The following is a description of a gene set: Mouse Gene Set: NABA_MATRISOME_HYPERPLASTIC_PANCREATIC_ISLETS species: Mus musculus from publication Naba A, Clauser KR, Mani DR, Carr SA, Hynes RO (PMID 28071719) Matrisome proteins detected in significantly higher abundance during the hyperplastic stage of insulinoma progression compared to normal islets and relative to insulinomas (RIP-Tag2 model). In this study, we aimed to characterize changes in the extracellular matrix (ECM) composition during insulinoma progression using a quantitative proteomics approach. To do so, we chose a mouse model of insulinoma, a subtype of pancreatic neuroendocrine tumors, characterized by the expression of SV40 large T antigen (Tag) in pancreatic beta-cells driven by the rat insulin promoter (RIP) (RIP1-Tag2 model). This model follows a well-defined timeline of tumor progression: hyperplastic islets appear by 4 weeks of age, angiogenic islets by 7-9 weeks, solid tumors at 10 weeks, and large and invasive adenomas by 12-13 weeks. Using quantitative proteomics based on isobaric peptide labeling (iTRAQ), we profiled the ECM proteomes or matrisomes of various stages: normal pancreatic islets, hyperplastic islets, angiogenic pancreatic islets, and insulinomas. We focused on ECM and ECM-associated proteins along with proteins found in only one of the two replicates but with at least two unique peptides. Applying a moderated F-test, we identified proteins detected in statistically significantly different abundance in tumor samples (hyperplastic, angiogenic islets or isulinomas) as compared to normal pancreatic islets. The gene set lists the matrisome proteins detected in significantly higher abundance during the hyperplastic stage of insulinoma progression as compared to normal islets and later stage insulinomas., and this is the list of marker genes: Prss1, Dmbt1, Serpini2 (NCBI Gene Id 67931), Vwa5a, Prss1l, Lgals1, Try10, Reg1, Reg2, Anxa3, Anxa7 (annexin A7), Cela2a, Cela1, Reg3g, Anxa6, Cela3b, Anxa11, Try4, Prss3, Lman1 (NCBI Gene Id 70361), Serpinb1a (NCBI Gene Id 66222), Dcn, F2, Hmcn1, Prss2, Ctsl